Given this list of marker genes BARHL2, MPV17L2 (NCBI Gene Id 84769), DHX9, EIF2B5, TNF, PRKCH, EIF5AL1, FASTKD3, PABPC1, MIURF, ZCCHC13, EIF2AK4, PRKDC, EIF4G3, SERP1, PINK1, DAZL, RPS6KB1, CTIF, SAMD4A, NSUN5, PKM (pyruvate kinase M1/2), SH3BGRL, LARP4, SSB, TRUB2, FXR2 (FMR1 autosomal homolog 2), EIF4A3, PRMT1, TARBP2, MIR16-1, CCL5, RPS4X, NAT10, PLXNB2 (plexin B2), RPUSD4, EIF3C, PCIF1, MTOR, RPL26, DHX29, SYNCRIP, MIF4GD, CSDE1, USP16, PPP1R15A, HNRNPD, NPM1, YBX3, POLR2G, GUF1, PYM1, DHX36, METTL8, NCK1, ERBB2, CIRBP, BCL3, RMND1, MIR15B, UQCC2, EIF3E, TRMT10C, RCC1L, RPUSD3, DNAJC3, OGT, DDX3X (NCBI Gene Id 730543), HABP4, LARP1, UCN, RBM4, RPL5, DAZ2, NGRN, IL6, YTHDF3, PIWIL2, RPS27L, METTL3, AGO2, FXR1, EIF5A2, EIF5A, KRT17, PLD1, POLDIP3, YTHDF1, RBMS3, LARP4B, METTL14, ITGA2, NCK2 (NCBI Gene Id 8440), HNRNPU, FMR1, BOLL, RPS6KB2, JMJD4, PKP1, AKT2, UHMK1, EIF4G1, FASTKD2, METTL5, TENT5B, NIBAN1, SMYD5, OTUD6B, KHDRBS1, PAIP1, CNBP, UPF3A, YBX1, TIFAB, COA3, LIN28A, ABCF1, LARP1B, PRR16, C1QBP, EIF6, ENSG00000293600 (novel protein), EEF2, DAZ4, PASK, CPEB3, ELAVL1, CD28, IGF2BP1, DAZ3, YTHDF2, THBS1, CDK5RAP1, RBM3, UPF3B, ZCCHC4, DAZ1, here is a description of the gene set: Any process that activates or increases the frequency, rate or extent of the chemical reactions and pathways resulting in the formation of proteins by the translation of mRNA or circRNA. Human Gene Set: GOBP_POSITIVE_REGULATION_OF_TRANSLATION species: Homo sapiens